The following is a description of a gene set: Any process that modulates the frequency, rate or extent of the formation and development of teeth, the hard, bony appendages which are borne on the jaws, or on other bones in the walls of the mouth or pharynx of most vertebrates. Human Gene Set: GOBP_REGULATION_OF_ODONTOGENESIS_OF_DENTIN_CONTAINING_TOOTH species: Homo sapiens, and this is the list of marker genes: BMP4, RSPO2, TNFRSF11B, BMP2, DMRT3, NGFR, APCDD1, WNT10A, CSF1 (colony stimulating factor 1), FGF8, RUNX2